Given this list of marker genes APOC2, ABCA1, APOA5, SPNS1, ABCA12 (NCBI Gene Id 3392), ABCA7, APOC3, ABCG1, APOA2, APOC1, APOA1, APOE, APOA4, ABCA3, here is a description of the gene set: Human Gene Set: GOBP_PHOSPHOLIPID_EFFLUX The directed movement of a phospholipid out of a cell or organelle. species: Homo sapiens